The following is a description of a gene set: from publication Chen Y, Wang X (PMID 31504780) Genes predicted to be targets of miRBase v22 microRNA hsa-miR-7854-3p in miRDB v6.0 with MirTarget v4 prediction scores > 80 (high confidence targets). studied in species Homo sapiens Human Gene Set: MIR7854_3P, and this is the list of marker genes: ARX, FADS1, NFAT5, SLC41A1, SNX20 (NCBI Gene Id 124460), GPC1, LTBP2, ECHDC2, AKT3, ZNF223, DNM3 (NCBI Gene Id 26052), ZSCAN22, DHRS4, CFL2, BLTP3A, INVS, ABCA10, MAPK14, SLC38A2, STXBP5L, DLGAP5, TNRC6B, ATRNL1, EXOC6 (NCBI Gene Id 54536), CDHR3, SLMAP, ANKH, ZNF460, ZC3H11A, NAMPT, PLD5, ANTXR1, SLC25A16, BICD2, ZNF473, FOXP3, ENPP1, OVOL1, HIRIP3, TMEM253, IGDCC4, FAM171A1, COMMD10, ITGA8, UHMK1, KSR2, AQP11, NXT2, MGAT2, HTR3A, RHOH, RIMS4, GEMIN5, XCL1, SFTA3, THRAP3, AKIRIN1, POT1, KLHL31, GARRE1 (NCBI Gene Id 9710), SEMA4F, NLRP8, ZNF225, RHNO1, DHRS4L2, EXT1, AMOT, ACTR1A, CPA4, ZNF618, PDE4D, UNC5D, ADGRF1, PLAGL2, ASB7, CMTM4, HDAC3, KLF13, RBM7, GATAD2A, CCNYL1, EVA1A, GTF2H1, STK32C, RAB14, PDS5B, GXYLT1, SDK2, CAT, ERFE, PKHD1L1, DAB1, ANKRD13A, STK40, INSIG1, HMMR, PRKAA2, FAM222B, KIAA1671, ADAM28, KATNAL1, HSPA5, COL4A6, INO80D, TMEM198, DHRS4L1, SAP30BP